Given this list of marker genes Nmt2, Zdhhc3, Sphk1, Ankrd11, Nat8f1, Naa50, Dip2b, Zdhhc20, Zdhhc8 (NCBI Gene Id 64503), Ppm1b, Aanat, Hhat (hedgehog acyltransferase), Smo, Selenok, Map6d1, Naa80, Kat2a, Sirt3, Klf15, Ep300, Hint2, Xbp1, Esco2, Kat2b, Zdhhc12, Naa20, Nfe2, Dscc1, Shh, Prkaa1, Kif3a, Nat8, Esco1, Smc5, Zdhhc14, Clip3, Ppm1a, Ddx3x, Ing4 (inhibitor of growth family, member 4), Zdhhc6, Cdyl, Taok1, D1Pas1, Mboat4, Nupr1, Golga7, Gsk3b, Hdac2, Bloc1s1, Naa60, Kat7, Naa16, Arid5a, Naa11, Nat10, Sox4, Kat5, Gtf2b, Zdhhc15 (zinc finger, DHHC domain containing 15), Naa15, Nmt1, Prkaa2, Sirt1, Zdhhc22, Atat1, Zdhhc23, Zdhhc11, Bag6, Bmal1, Zdhhc21, Ing5, Zdhhc18, Zdhhc16, Zdhhc7, Nat8f7, Zdhhc2, Clock, Zdhhc17, Park7, Fcor, Porcn, Zdhhc5, Zdhhc1, Nat8b-ps, Naa10, Hhatl, Glul, Dip2a, Fam161a, Naa12, Zdhhc19, Zdhhc9, Kat6a, Pml, Crebbp, Cep295, here is a description of the gene set: Mouse Gene Set: GOBP_PROTEIN_ACYLATION studied in species Mus musculus The addition of an acyl group, any group or radical of the form RCO- where R is an organic group, to a protein amino acid.